Given this list of marker genes TTLL8, FPGS, LGSN, TTLL2, GCLC, TPGS1, TTLL12, ADSS1, TTLL3, TTLL7 (tubulin tyrosine ligase like 7), NAPRT, ASNS, CPS1, QRSL1, TTLL5, GHDC, GCLM, GART, ASS1, PPCS, TTL, MCCC1, MTHFS, PFAS, DPH6, CAD, RIMKLB, CARNS1, TTLL13, NADSYN1, TTLL9, MTHFD1, GLUL, GATC, HLCS, GATB, CTPS2, TTLL1, CTPS1, ADSS2, PAICS, TTLL4, GMPS, RIMKLA, ASNSD1, TTLL6, TTLL11, MTHFD1L, GSS, TTLL10 (tubulin tyrosine ligase like 10), here is a description of the gene set: Catalysis of the joining of two molecules, or two groups within a single molecule, via a carbon-nitrogen bond, with the concomitant hydrolysis of the diphosphate bond in ATP or a similar triphosphate. studied in species Homo sapiens Human Gene Set: GOMF_LIGASE_ACTIVITY_FORMING_CARBON_NITROGEN_BONDS